The following is a description of a gene set: Human Gene Set: HP_SHORT_5TH_TOE Underdevelopment (hypoplasia) of the fifth toe. Short 5th toe species: Homo sapiens, and this is the list of marker genes: COX4I1, EP300, DYRK1A, TBX3, RBPJ